Given this list of marker genes Capn10, Prkcd, Oxct1, Ep300, Crh, Prkce, Nkx6-1, Gprc6a, Anxa7, Pard6a, Tmem97, Tlr4, Tsg101, Ghrl, Oaz2, Ywhae, Mpc2, Hdac3, Cep131, Arf6, Chrm1, Orai1, Pdcd5-ps, Sox4, Blk, Mavs, Rack1 (receptor for activated C kinase 1), Fgb, Gip, Pik3r1, F2, Myh9, Arf1, Sirt1, Atp13a2 (NCBI Gene Id 74772), Cln3, Atp2c1, Ptbp1, Ins2, Ang, C2cd2l, Gck, Oga, Zfp384, Dctn1, Tpr, Mcu, Serp1, Gas6, Uaca, Prkn (NCBI Gene Id 50873), Tenm1, Src, Chp1, Gcg, Pdcd5, Il6, Irs2, Mmp13, Hcls1, Gsk3b, Ppia, Egfr, Zdhhc2, Cacna1c, Snap25 (synaptosomal-associated protein 25), Vamp8, Pparg, Arrb1, Kif3a, Tmem30b, Akap5, Tnfrsf1a, Shh, Rbp4, Ppp3cb, Prkcq, Xbp1, Tgfb3, Lep, Tm9sf4, Trim28, Rapgef4, Kif5b, Prkaca, Ncoa6, Sorl1, Rab34, Or51e2, Ptpn23, Nr1h2, Efcab7, Hcfc1, Mlxipl, Casr, Vps28, Cep290, Hyal2, Malrd1, Ect2, Brca1, Ppm1a, Pck2, Nutf2, Wls, Arhgef5, Edem1, Rbm22, Psmd9 (proteasome (prosome, macropain) 26S subunit, non-ATPase, 9), Bsg, Ifng, Hnf1a, Edem2, Tunar, Oaz3, Tgfb1, Gnas, Tcf7l2, Abcc8, Gper1, Fga, Asph, Agt, Ctdspl2, Sybu (NCBI Gene Id 319763), Doc2b, Adam9, Ptpn22, Vps35, Rapgef3, C1qtnf3, Bad, Sirt3, Prpf4b, Acsl4, Hsp90ab1, Kif20b, Bcap31, Xpo4, Camk2n1, Slc30a8, Rab29, C1qtnf12, Wipf1, Tmem132a, Cask, Pcnt, Gli3, Rufy3, Sirt6, Sfn, Nadk (NAD kinase), Slc51b, Pgrmc1, Sytl4, Cd2ap, Trh, Trpm5, Lrrc8a (NCBI Gene Id 279036), Tomt, Isl1 (ISL1 transcription factor, LIM/homeodomain), Prr5l, Camk1, Prkar1a, Pla2g6, Mapk14, Commd1, Gpr68, Sec16b, Apbb3, Ripor1, P2rx7, Dmap1, App, Cnst, Plk3, Lrp2, Ubr5, Gipr, Ergic3, Pik3r2, Rac1, Nnat, Ucn3, Gpld1, Emd, Glul, Stx4a, F2rl1, Acsl3, Vsnl1, Myh10, Myom1, Zc3h12a, Tmed10, Zpr1, Oaz1, Kcnn4, Bglap2 (NCBI Gene Id 12097), Ang6, Mapk1, Nr1h4 (nuclear receptor subfamily 1, group H, member 4), Nmu, Cacna1d, Cftr, Pcsk1, Lrp1, Golph3, Mdm2, Dynll1, Ran, Fgg, Ankrd1, Stim1, Pcm1 (pericentriolar material 1), Nutf2-ps1, Abcg1, Trpm4, Ier3ip1, Vamp2, Ang2, Adcy8, Smo, Ffar1, Rfx6, Ano1, Gna11, F2rl2, Fto, Anp32b (NCBI Gene Id 67628), Itpr1, Ppid (peptidylprolyl isomerase D (cyclophilin D)), Prkcb, Ppard, Zic1, Dnm1l, Eif3e, Sec24a, Tmed10-ps, Gpr39, Ang5, Glud1, Trpm2, Tnf, Hsp90aa1, Ttn, Myrip, Il13, Hcar2, Tgfb2, Psen1, Trpc1, Cd81, Cdk1, Hif1a, Exph5, Chp2, Chrm3, B3gat3, Flna, Abat, Slc35d3, Ptgs2, Adora2a, Osbp, Apbb1, Jak2, Pfkfb2, Unc13b, Prkcz, Gja1, Ptger4 (NCBI Gene Id 19219), Camk4, Zfand1, Jup, Plcb1, Hnrnpm, Golph3l, Tm7sf3, Nr0b2, Slc2a2, Lepr, Vegfc, Tlr2, Rph3al, Glp1r, Ptpn5, Igf1 (insulin-like growth factor 1), Baiap3, Apoe, Atg7, Cdc42, Gnaq, Il1a, Pdcd10, Tardbp, Ipo5, Cd38, Ins1, Bag3, Ice1, Pfkm, Aacs, A1cf, Ffar2, Cdh1, Prkd1, Trem2, Frmd4a, Trpa1, Gpr27, Pdx1, Ang4, Tek (TEK receptor tyrosine kinase), Nlgn2, Myo18a, Tmem30a, here is a description of the gene set: Any process that activates or increases the frequency, rate or extent of the directed movement of a protein into, out of or within a cell, or between cells, by means of some agent such as a transporter or pore. species: Mus musculus Mouse Gene Set: GOBP_POSITIVE_REGULATION_OF_PROTEIN_TRANSPORT